Given this list of marker genes Atp10a, Sh3glb1, Wasl, Asap1, Dnm2, Sh3gl2, here is a description of the gene set: Mouse Gene Set: GOBP_REGULATION_OF_MEMBRANE_TUBULATION Any process that modulates the frequency, rate or extent of membrane tubulation. species: Mus musculus